The following is a description of a gene set: Human Gene Set: GOBP_FOREBRAIN_VENTRICULAR_ZONE_PROGENITOR_CELL_DIVISION The mitotic division of a basal progenitor giving rise to two neurons. studied in species Homo sapiens, and this is the list of marker genes: POU3F3, FGFR2, POU3F2, FGFR1, DCT, DIXDC1